Given this list of marker genes Frs2, Ntrk2, Ntf5, Sos1, Grb2, Bdnf, here is a description of the gene set: Mouse Gene Set: REACTOME_ACTIVATED_NTRK2_SIGNALS_THROUGH_FRS2_AND_FRS3 Activated NTRK2 signals through FRS2 and FRS3 species: Mus musculus